The following is a description of a gene set: The process in which nucleated precursor cells lose their nucleus. species: Mus musculus Mouse Gene Set: GOBP_ENUCLEATION, and this is the list of marker genes: Diaph3, Bloodlinc, Rac1, Ehbp1l1, Hdac6, Nemp1, Rac2, Trim58